Given this list of marker genes RPS12, CAMP, NUCB1, HDGF, PSMC5, PTPN2, LYL1, RPL41, DYNC1H1, PRG2, IL3RA, VCAM1, EPX, CTDSP2, MAP4K4, VAMP8, CD63, GATA1, PRG3, IL11RA, ETF1, TSPAN32, SET, NELFE, GTF3C1, HIP1R, GORASP2, SERPINB2, DOK2, TACSTD2, POLR2L, CTSH, RNASE3, NUCB2, GATA2, E2F1, STX3, IKBKB, RBBP4, HDAC2, ALOX15, NFKB1, here is a description of the gene set: studied in species Mus musculus Genes whose expression in bone marrow samples correlated directly with increased levels of serum IL5. Human Gene Set: BYSTROEM_CORRELATED_WITH_IL5_UP from publication Byström J, Wynn TA, Domachowske JB, Rosenberg HF (PMID 14525773) Interleukin-5 (IL-5) is a hematopoietic differentiation factor that promotes the development of mature eosinophils from progenitors in bone marrow. We present a multifactorial microarray study documenting the transcriptional events in bone marrow of wild-type and IL-5-deficient mice at baseline and in response to infection with Schistosoma mansoni. The microarray data were analyzed by a 4-way subtractive algorithm that eliminated confounding non-IL-5-related sequelae of schistosome infection as well as alterations in gene expression among uninfected mice. Among the most prominent findings, we observed 7- to 40-fold increased expression of transcripts encoding the classic eosinophil granule proteins (eosinophil peroxidase, major basic protein, the ribonucleases) together with arachidonate-15-lipoxygenase and protease inhibitor plasminogen activator inhibitor 2 (PAI-2), in the IL-5-producing, infected wild-type mice only. This was accompanied by increased transcription of genes involved in secretory protein biosynthesis and granule-vesicle formation. Interestingly, we did not detect increased expression of genes encoding eosinophil-related chemokine receptors (CCR1, CCR3) or members of the GATA or CCAAT/enhancer binding protein (C/EBP) transcription factor families. These data suggest that the IL-5-responsive progenitors in the mouse bone marrow are already significantly committed to the eosinophil lineage and that IL-5 promotes differentiation of these committed progenitors into cells with recognizable and characteristic cytoplasmic granules and granule proteins.